The following is a description of a gene set: part of: Downstream signaling of activated FGFR1 studied in species Homo sapiens The FRS family of scaffolding adaptor proteins has two members, FRS2 (also known as FRS2 alpha) and FRS3 (also known as FRS2beta or SNT-2). Activation of FGFR tyrosine kinase allows FRS proteins to become phosphorylated on tyrosine residues and then bind to the adaptor GRB2 and the tyrosine phosphatase PPTN11/SHP2. Subsequently, PPTN11 activates the RAS-MAP kinase pathway and GRB2 activates the RAS-MAP kinase, PI-3-kinase and ubiquitinations/degradation pathways by binding to SOS, GAB1 and CBL, respectively, via the SH3 domains of GRB2. FRS2 acts as a central mediator in FGF signaling mainly because it induces sustained levels of activation of ERK with ubiquitous expression.<br><br><br> Reactome Pathway: FRS-mediated FGFR1 signaling, and this is the list of marker genes: FGF5, PTPN11, FGFR1 (NCBI Gene Id 84151), FGF9, KRAS, FRS3, FGF17, FGF2, KL, FGF23, FGF1 (NCBI Gene Id 29961), FGF6, FGF8, FGF20, FGF4, FGF10, SOS1, FGF3, NRAS, FRS2, GRB2, FGF22, HRAS